Given this list of marker genes RFNG, MFNG, NOTCH3, ATP2A1, RAB6A, FURIN, NOTCH1, B4GALT1, NOTCH2, ST3GAL4, LFNG, TMED2, ATP2A3, SEL1L, ATP2A2, ST3GAL3, NOTCH4, ST3GAL6, here is a description of the gene set: part of: Pre-NOTCH Expression and Processing NOTCH undergoes final posttranslational processing in the Golgi apparatus. Movement of NOTCH precursors from the endoplasmic reticulum to Golgi is controlled by SEL1L protein, a homolog of C. elegans sel-1. SEL1L localizes to the endoplasmic reticulum membrane and prevents translocation of misfolded proteins, therefore serving as a quality control check. Similarly, C. elegans sel-9 and its mammalian homolog TMED2 are Golgi membrane proteins that participate in quality control of proteins transported from Golgi to the plasma membrane. Translocation of a mutant C. elegans NOTCH homolog lin-12 from the Golgi to the plasma membrane is negatively regulated by sel-9. A GTPase RAB6 positively controls NOTCH trafficking through Golgi. <br><br> <br>Processing of mammalian NOTCH precursors in the Golgi typically involves the cleavage by FURIN convertase. Pre-NOTCH is a ~300 kDa protein, and cleavage by FURIN produces two fragments with approximate sizes of 110 kDa and 180 kDa. The 110 kDa fragment contains the transmembrane and intracellular domains of NOTCH and is known as NTM or NTMICD. The 189 kDa fragment contains NOTCH extracellular sequence and is known as NEC or NECD. The NTM and NEC fragments heterodimerize and are held together by disulfide bonds and calcium ions. <br> <br> <br>An optional step in Pre-NOTCH processing in the Golgi is modification by fringe enzymes. Fringe enzymes are glycosyl transferases that initiate elongation of O-linked fucose on fucosylated peptides by addition of a beta 1,3 N-acetylglucosaminyl group, resulting in formation of disaccharide chains on NOTCH EGF repeats (GlcNAc-bet1,3-fucitol). Three fringe enzymes are known in mammals: LFNG (lunatic fringe), MFNG (manic fringe) and RFNG (radical fringe). LFNG shows the highest catalytic activity in modifying NOTCH. Fringe-created disaccharide chains on NOTCH EGF repeats are further extended by B4GALT1 (beta-1,4-galactosyltransferase 1), which adds galactose to the N-acetylglucosaminyl group, resulting in formation of trisaccharide Gal-beta1,4-GlcNAc-beta1,3-fucitol chains. Formation of trisaccharide chains is the minimum requirement for fringe-mediated modulation of NOTCH signaling, although fringe-modified NOTCH expressed on the cell surface predominantly contains tetrasaccharide chains on EGF repeats. The tetrasaccharide chains are formed by sialyltransferase(s) that add sialic acid to galactose, resulting in formation of Sia-alpha2,3-Gal-beta1,4-GlcNAc-beta1,3-fucitol. Three known Golgi membrane sialyltransferases could be performing this function: ST3GAL3, ST3GAL4 and ST3GAL6. The modification of NOTCH by fringe enzymes modulates NOTCH-signaling by increasing the affinity of NOTCH receptors for delta-like ligands, DLL1 and DLL4, while decreasing affinity for jagged ligands, JAG1 and JAG2. Reactome Pathway: Pre-NOTCH Processing in Golgi studied in species Homo sapiens